The following is a description of a gene set: Binding to an amino acid, organic acids containing one or more amino substituents. Human Gene Set: GOMF_AMINO_ACID_BINDING species: Homo sapiens, and this is the list of marker genes: TM4SF5, NOS2, GLUD1, GLRB, TDO2, CASTOR1, GRIN1, KARS1 (lysyl-tRNA synthetase 1), UBR2, GLUD2, GLRA2 (NCBI Gene Id 2742), GCLC, SLC1A3, YARS2, GRIN2B (glutamate ionotropic receptor NMDA type subunit 2B), GRIN3A, TAT, SLC7A6, CASR, SCLY, CAD, GLDC, SHMT2, GRM7, NOS3, THNSL2 (threonine synthase like 2), ASS1, AGXT, CASTOR2, OTC, UBR1, GLRA1, GNMT, SLC38A9, GRIN3B, RARS1, CPS1, GLRA3, SESN1, GPR143, GRIN2D, SESN3, DDAH1, AARS1, SESN2, NOS1, SLC6A11, SRR, SHMT1